The following is a description of a gene set: species: Homo sapiens Abnormal monocyte morphology Human Gene Set: HP_ABNORMAL_MONOCYTE_MORPHOLOGY Any structural anomaly of a myeloid mononuclear recirculating leukocyte that can act as a precursor of tissue macrophages, osteoclasts and some populations of tissue dendritic cells., and this is the list of marker genes: RAC2, ARPC5, IKBKB, G6PC3, SRP68, WAS, GFI1, ZNFX1, GATA2, SRP19, CARD11, ELANE, CLPB, DDX41, KRAS, TCIRG1, PIK3CG, PIK3CD, SEC61A1 (NCBI Gene Id 83289), IRF8, NRAS